Given this list of marker genes ATP6V1H, NCBP1, GFAP, MAPKAP1, SH3GL1, CALM1, NCF1, PSEN2, BRK1, FOS, PRKACA, NCOR1, LAMA5, PTPRO, EPGN, CYBB, WASF2, AP2A2, TLR9, APH1A, ROCK2, ESR1 (NCBI Gene Id 2099), MKNK1, PTPN1, NRAS, NRG3, CTNNA1, CYFIP1, NTRK2, FGFBP1, YAP1, RAPGEF1, ATP6V0E1, ATP6V1B2, SH2D2A, PIK3CA (NCBI Gene Id 5290), PPP2CA, PAG1, COL4A5, PDGFRB, COL1A2, AP2S1, NRP1, POLR2I, HGS, NRG1, PCSK5, MTOR (NCBI Gene Id 2476), DUSP7, STAT6, PSEN1, BCAR1, PRKCB, PGR, KL, MEF2C, FGF4, SRF, CDC42 (NCBI Gene Id 998), PIK3R2, FGFR2b, LAMA4, COL3A1, COL6A2, MST1R, ATP6V0A1, GRAP2, AREG, RAB4A, RAC1, REST (RE1 silencing transcription factor), PAK1, TRIB1, SHC1, IL2RG, PTPRU, MAPK11, POLR2E, ALKAL1, ATP6V0E2, CUL5, UBB, PTPN11, DUSP3, LAMB3, IRS4, VGF, EP300, POLR2F (RNA polymerase II, I and III subunit F), TNS3, MAPK13 (NCBI Gene Id 5603), RALGDS (NCBI Gene Id 95849), IRS2, SHC2, TGFBR3, FGF1, S100B, FES, LAMB1, FGF10, MEF2D, SOCS6, GABRB1, BDNF, NAB1, NELFB, BAX, NCSTN (NCBI Gene Id 57297), POLR2B, WASF1, PTPRK, PIK3CB, ALK, HDAC1 (NCBI Gene Id 3065), ATP6V1G2, RIT2, FGFR4, ATF1, NCKAP1, RPS6KA2, GTF2F1, HSPB1, SPHK1, THEM4 (thioesterase superfamily member 4), SH2B2, SPRED2 (NCBI Gene Id 200734), FN1, RALA, NGF (nerve growth factor), NCKAP1L, CAV1, PTK6, NRG2, YES1, PTPRS, RAP1A, ATP6V1E2, HNRNPA1, EGR1, USP8, HNRNPM, IRS1, BTC, TCF12, POLR2K, POLR2J, MAP2K2, RPS6KA3, FGF5, NCBP2, FLRT1, ANOS1, SHB, PAK3, FRS3, ERBIN, FGFRL1, CTNND1, STAT3, LYL1, SH3KBP1, FOSB (FosB proto-oncogene, AP-1 transcription factor subunit), AKT3, WWP1, PXN, PTN, LAMA3, ATP6V1F, ATP6V1G1, SIN3A, COL6A3, VRK3, COL11A2, MUC20, BAIAP2, VEGFB, BRAF, FGF19, ATP6V0A4, DOCK7, ESRP1, RANBP10, WWOX, NCK1, NTRK3, RPS27A, ATP6V0D1 (NCBI Gene Id 9114), ITGB1, COL9A1, ADCYAP1, TNS4, PPP2R1B, MLST8, EPN1, MAPKAPK2, AHCYL1, MAPK3, STAT1, ACTB, KITLG, STAM2, PDGFB, FGF2, RAP1B, RHOA, GABRG3, PTK2B, ATP6V1G3, HGFAC, RPS6KA1, ID4, PTPRZ1, THBS1, GABRB3, PGF, COL6A6, GRB7, CDH5, GRAP (GRB2 related adaptor protein), FGFR3, GABRA1, ELMO2, ERBB4 (erb-b2 receptor tyrosine kinase 4), PIK3R4, ID3, PTPN2, TAB2, M, FLRT2, KIT, NTF3, STUB1, ATP6V0A2, PTPN3, LRIG1, NRG4, PRKCD, COL5A1, LAMC2, TPH1, FGFBP2, AP2B1, ATP6V0B, AAMP, COL4A2, LAMC3, DNM2, IGF1R, STAT5A, CTNNB1, PRDM1 (NCBI Gene Id 639), IDE, ACTG1, PRKACB, RALB, FER, FGF7, FLT3LG, HNRNPF, FGF18, GRIN2B, ITPR2, AXL, APOE, PPP2R5D, JAK2, STMN1, EPS15 (epidermal growth factor receptor pathway substrate 15), FGF20, CILP, APH1B, LAMA1, INSR, PTPN6, POLR2C, CSK, DNM1, FGF3, RANBP9, PSENEN, SPRY1, FGF23, ATP6V1D, GGA3, HPN, CSN2, HNRNPH1, PTPRJ (NCBI Gene Id 5795), ARF6, GABRQ, RNF41, NCF4, CYFIP2, COL5A2, PDPK1, ITCH, TEC, FAM83D, SOCS1, FYN, MYCN, EREG, FOSL1, COL27A1, LYN, INS, ROCK1, HBEGF (heparin binding EGF like growth factor), PIK3R3, ADAP1, HDAC2, ATP6V0D2, LAMC1, WASF3, HIF1A, JUP, FLT4, GAB1, ATP6V1C1, CDK5R1, LTK, RASA1, COL4A4, ERBB2, ITGA2, AP2A1, ADORA2A, FGF6, CREB1, COL5A3, ATP6V0C, ADCYAP1R1, EGR3, CDK5, SPINT2, VEGFC, COL2A1, FGF22, COL6A5, ITGA3, CBL, PTK2, MAPK14, SPARC, PTPN12, ITGB3, YWHAB, DUSP6, CMA1, PLCG1, EGF, RPS6KA5, THBS2, HGF, COL1A1, ATP6V1C2, COL4A1, LAMB2, AP2M1, DIAPH1, RAB4B, CHEK1 (checkpoint kinase 1), AKT2, COL6A1, NEDD4, CRK (NCBI Gene Id 1398), ERBB3, EGFR, IGF1, ITGAV, FGF17, ADAM10, MMP9, PAK2, SH3GL2, DOCK1, FLT3, MAPK7, ATF2, LAMA2, DUSP4, GALNT3, VAV2, MAPK12, EPS15L1, COL4A3, FGF9, FGFR2, MEMO1, TIAL1, SPRED1, VAV3, KDR, PDGFA, FURIN, SGK1, PCSK6, STAT5B, FRS2, PTPRF, MYC, HSP90AA1, FLT1, CD274, MAPK1, PLG, DOCK3, ESRP2, KLB, PRKCA (protein kinase C alpha), KRAS, SOS1, ARHGEF7, PDGFC, NOS3 (nitric oxide synthase 3), JUNB, SHC3, SRC, MXD4, FGF16 (fibroblast growth factor 16), RIT1, ASCL1, LCK, VAV1, EGR4, NAB2, SH3GL3, HDAC3, MATK (megakaryocyte-associated tyrosine kinase), PDGFD, NTF4, TNK2, THBS4, ELMO1, NCF2 (neutrophil cytosolic factor 2), ADAM17, MEF2A, SH2B3, CDC37, PDE3B, IGF2, GABRG2, MAPKAPK3, CLTC, COL24A1, PRKCZ, AKT1, CTSD, FAM83A, EGR2, GRB10, CDK5R2, FLRT3, POLR2G (NCBI Gene Id 5436), ABI1, TRIB3, PLAT, STAM, THBS3, PPP2CB, GIPC1, FGF8, PRKCE, MET, UBA52, NTRK1, VEGFD, ALKAL2, PRR5, N, ITPR1, SPP1, POLR2A, GTF2F2, TCIRG1, MAP2K5, FAM83B, NCK2, CXCL12, FGFR1, ATP6V1E1, CLTA, HRAS, VEGFA, ITPR3, CYBA, DLG4, PDGFRA, MAP2K1, ADAM12, PRKACG, TIAM1, KIDINS220, POLR2L, CRKL, POLR2H, PTBP1, PTPN18, UBC, MDK, TGFA, COL11A1, SPRY2, ATP6V1B1, DNM3, MST1, GAB2, PPP2R1A, POLR2D, ATP6AP1 (ATPase H+ transporting accessory protein 1), ELK1, DNAL4, F3, TIA1, RBFOX2, ATP6V1A, ABI2, DNMT1, ARC, NRP2, RICTOR, CHD4, GRB2, JUND, FGFR2c, FGFBP3 (NCBI Gene Id 143282), SPINT1, ID1 (NCBI Gene Id 96820), COL9A2, ID2, GABRB2, PIK3R1, JAK3, COL9A3, RRAD, PIK3C3, here is a description of the gene set: part of: Signal Transduction studied in species Homo sapiens Receptor tyrosine kinases (RTKs) are a major class of cell surface proteins involved in Signal Transduction. Human cells contain ~60 RTKs, grouped into 20 subfamilies based on their domain architecture. All RTK subfamilies are characterized by an extracellular ligand-binding domain, a single transmembrane region and an intracellular region consisting of the tyrosine kinase domain and additional regulatory and protein interaction domains. In general, RTKs associate into dimers upon ligand binding and are activated by autophosphorylation on conserved intracellular tyrosine residues. Autophosphorylation increases the catalytic efficiency of the receptor and provides binding sites for the assembly of downstream signaling complexes (reveiwed in Lemmon and Schlessinger, 2010). Common signaling pathways activated downstream of RTK activation include RAF/MAP kinase cascades, AKT signaling and PLC-gamma mediated signaling. Activation of these pathways ultimately results in changes in gene expression and cellular metabolism. Reactome Pathway: Signaling by Receptor Tyrosine Kinases